Given this list of marker genes PNP, ADA, GRM5, ADSL, TPMT, PAICS, AOX1, HPRT1, RRM2B, GART, ATIC, MAT2A (methionine adenosyltransferase 2A), AMPD1, APRT, ADSS2, MOCOS, PFAS, PRPS1, PPAT, XDH, IMPDH1, ITPA, DGUOK, here is a description of the gene set: Human Gene Set: WP_PURINE_METABOLISM_AND_RELATED_DISORDERS Purine metabolism and related disorders species: Homo sapiens